The following is a description of a gene set: Transcription factors represent an important class of genes that play key roles in controlling cellular proliferation, cell cycle modulation, and attractive targets for cancer therapy. Here, we report on the novel finding of common ATF5 down-regulations in hepatocellular carcinoma (HCC), a highly malignant tumor with a dismal clinical course. Array-based mapping in HCC highlighted a high and consistent incidence of transcription factor ATF5 repressions on regional chr.19q13. By quantitative reverse transcription-PCR, profound down-regulations of ATF5 were further suggested in 78% of HCC tumors (60 of 77 cases) compared to their adjacent nontumoral liver (P = 0.0004). Restoration of ATF5 expression in 3 nonexpressing HCC cell lines demonstrated a consistent growth inhibitory effect (P < 0.029) but minimal induction on cellular apoptosis. Subsequent flow cytometric investigations revealed a G(2)-M cell cycle arrest in HCC cells that were ectopically transfected with ATF5 (P < 0.002). The differential expressed genes from the functional effects of ATF5 were examined by array profiling. Over a hundred genes were identified, among which ID1 contains the ATF/CREB target binding sequences within its promoter region. An inverse relationship between ATF5 expressions with ID1 transcriptions was verified in HCC (P = 0.019), and a direct interaction of ATF5 on the promoter of ID1 was further demonstrated from electromobility shift assay. Examination of causal events underlying the silencing of ATF5 in HCC suggested copy number losses, promoter hypermethylation, histone deacetylation, and DNA mutations to be the likely inactivating mechanisms. In conclusion, our finding supports a tumor suppressive role for ATF5 in HCC, and highlighted ID1 as a potential downstream target. from publication Gho JW, Ip WK, Chan KY, Law PT, Lai PB, Wong N (PMID 18701499) Genes down-regulated in HEP3B cells (liver cancer) overexpressing ATF5 off a plasmid vector. Human Gene Set: GHO_ATF5_TARGETS_DN studied in species Homo sapiens, and this is the list of marker genes: TRIP13 (NCBI Gene Id 9319), ACTN4, TECR, SLC2A1, BTN3A2, YWHAH, ID1, RND3, DUSP1, RPN1, ITGA5, CCND3, ITGA2, TMED9, RRAS, KIF20A